The following is a description of a gene set: Adipocyte genes induced in 3T3-L1 cells (adipocyte) by constitutively active PPARG or its agonist, TZD. species: Mus musculus The PPARgamma is a key adipogenic determination factor. Ligands for PPARgamma such as antidiabetic thiazolidinedione (TZD) compounds are adipogenic, and many adipocyte genes that are activated by TZDs contain binding sites for PPARgamma. Like ligands for other nuclear receptors, TZDs can regulate genes positively or negatively. Here, we sought to understand the importance of positive regulation of gene expression by PPARgamma in adipogenesis. Fusion of the potent viral transcriptional activator VP16 to PPARgamma2 (VP16-PPARgamma) created a transcription factor that constitutively and dramatically activated transcription of PPARgamma-responsive genes in the absence of ligand. Forced expression of VP16-PPARgamma in 3T3-L1 preadipocytes using retroviral vectors led to adipogenesis in the absence of standard differentiating medium or any exogenous PPARgamma ligand. Gene microarray analysis revealed that VP16-PPARgamma induced many of the genes associated with adipogenesis and adipocyte function. Thus, direct up-regulation of gene expression by PPARgamma is sufficient for adipogenesis. TZD-induced adipogenesis up-regulated many of the same genes, although some were divergently regulated, including resistin, whose gene expression was reduced inVP16-PPARgamma adipocytes treated with TZDs. These results show that, although activation of PPARgamma by a heterologous activation domain is sufficient for adipogenesis, it is not equivalent to TZD treatment. This conclusion has important implications for understanding biological effects of the TZDs on adipogenesis and insulin sensitization. Human Gene Set: LI_ADIPOGENESIS_BY_ACTIVATED_PPARG from publication Li Y, Lazar MA (PMID 11981038), and this is the list of marker genes: CFD, GPD2, RETN, PC, LIPE, NR1H2, PPARG, AOC3, NR1H3 (NCBI Gene Id 113429), ADRB3, ADIPOQ, FABP4, SCD, DGAT1, AGT (angiotensinogen), FASN, ACSL1, CEBPA